The following is a description of a gene set: Binding to a protein or protein complex when at least one of the interacting partners is in the GTP-bound state. studied in species Homo sapiens Human Gene Set: GOMF_GTP_DEPENDENT_PROTEIN_BINDING, and this is the list of marker genes: HPS6, RAB38, AP3B1, CDC42, RAB3B, RAPGEF6, RAC1 (NCBI Gene Id 5879), DNM1L, RAPGEF5, RAB3A, ARFIP2, RAB5B, UNC13B, AP1G1, EEA1, RAB3C, MRAS, RAB3D, RAB34, PARD6A, RAB32